The following is a description of a gene set: Human Gene Set: HP_ABNORMAL_BRAIN_POSITRON_EMISSION_TOMOGRAPHY studied in species Homo sapiens Abnormal brain positron emission tomography A functional brain anomaly detectable by positron emission tomography (PET). PET scanning is a method for functional brain imaging, and its measurements reflect the amount of brain activity in the various regions of the brain., and this is the list of marker genes: CHMP2B, AKT1, TMEM106B, TERT, PSEN2, VCP, PSEN1, MAPT, TRANK1 (tetratricopeptide repeat and ankyrin repeat containing 1), SQSTM1, TREM2, GRN, PIK3CA, PRNP, SMARCB1, BAP1 (NCBI Gene Id 8314), COQ2, PDGFB, NF2, SMO, TRAF7, APOE, SUFU, SMARCE1